Given this list of marker genes HLA-DMA, KLF15, TNNC2, BHMT, C4BPA, MTARC1, KYNU, CRISP2, COA3, ELOVL5, TRPV2, ACOX1, ORM1, RGS16, EPHX2 (NCBI Gene Id 2053), CPT2, NETO2, CA5A, CYP4F2, GOT1, HAO1, G6PC1, HPD, GPR37, NR1H3, MAPKAPK2, HSD17B10, ORM2, SLC27A5, ZC2HC1C, AASS, LIPC, BAAT, IGF1, CYP7B1, FABP2, OAT, ABAT, ABCG2, SLC25A22, HAL (NCBI Gene Id 3034), EGFR, OTC, ALDH1A1, IL1RAP, CA3, DCT, IGFALS, G0S2, ALAS2, KHK, MCM10, PSEN2, HSD11B1, RGN, PXMP2, AQP8, FABP1, CYP2F1, MMD, PTP4A3, TDO2, CMAHP, ETNK2, PCK1, here is a description of the gene set: Human Gene Set: LEE_LIVER_CANCER_MYC_TGFA_DN Genes down-regulated in hepatocellular carcinoma (HCC) tissue of MYC and TGFA double transgenic mice. studied in species Homo sapiens from publication Lee JS, Chu IS, Mikaelyan A, Calvisi DF, Heo J, Reddy JK, Thorgeirsson SS (PMID 15565109) Genetically modified mice have been extensively used for analyzing the molecular events that occur during tumor development. In many, if not all, cases, however, it is uncertain to what extent the mouse models reproduce features observed in the corresponding human conditions. This is due largely to lack of precise methods for direct and comprehensive comparison at the molecular level of the mouse and human tumors. Here we use global gene expression patterns of 68 hepatocellular carcinomas (HCCs) from seven different mouse models and 91 human HCCs from predefined subclasses to obtain direct comparison of the molecular features of mouse and human HCCs. Gene expression patterns in HCCs from Myc, E2f1 and Myc E2f1 transgenic mice were most similar to those of the better survival group of human HCCs, whereas the expression patterns in HCCs from Myc Tgfa transgenic mice and in diethylnitrosamine-induced mouse HCCs were most similar to those of the poorer survival group of human HCCs. Gene expression patterns in HCCs from Acox1(-/-) mice and in ciprofibrate-induced HCCs were least similar to those observed in human HCCs. We conclude that our approach can effectively identify appropriate mouse models to study human cancers.